The following is a description of a gene set: Limb joint contracture species: Homo sapiens Human Gene Set: HP_LIMB_JOINT_CONTRACTURE A contracture (chronic loss of joint motion due to structural changes in muscle, tendons, ligaments, or skin) that prevent normal movement of one or more joints of the limbs., and this is the list of marker genes: PDGFRB, CPT2, BCAS3, OSGEP, PSMB8, KY, PQBP1, FGD1, DLG5, PDXK, ERCC6, ACTG2, TGFBR1, PEX1, COX11, PIK3R2, CAPN3, ALG3, GABRD, COL11A1, SNUPN (NCBI Gene Id 10073), CDC45, SNAP25, F8 (coagulation factor VIII), COL11A2, NUP88, RERE, DVL3, SLC18A3, CCN2, KCNAB2, OCRL, RSPO2, ALG2, NFATC2, COL12A1, NXN, ORAI1, SCN4A, CADM3, ORC4, TRIM2, SMAD2, C18orf32, SMAD3, PHGDH, RTL1, KCNJ11 (NCBI Gene Id 3767), SNRPB, WDR26, UBE4B, FZD2, MED11, CRKL, SMG9, CTCF, INS, PYCR1, REEP1, KIF21A, IPO8, SLC29A3, DSP, TBX15, EIF5A, ERCC5, COG5, PYROXD1, HSPG2, L1CAM (NCBI Gene Id 4268), HNRNPA2B1, IRF5, PI4KA, SIGMAR1, FHL1, SMOC1, JARID2, FERMT1, PIGA, DDHD2, DPM1, MUSK, GNPAT, KRT1, HES7 (NCBI Gene Id 84667), PLEKHG5, GMNN, ARID1B, ALAD, TBX2, CSGALNACT1, HNRNPA1, HSPB1, DNM2, FBXO28, SPTBN4, OPA1, SLC26A2, TRPS1, RIPPLY2, IGHMBP2, NGLY1, KMT2A, FKBP10, MYOD1, EMG1, COG8, ASXL1, RBM28, TPRKB, PORCN, GDAP1, DYRK1A, HACD1, ADAMTSL2 (ADAMTS like 2), STAT3, ATP6V1E1, HINT1, SLC10A7, SPG11, FBN2, ERCC1, IGF2 (NCBI Gene Id 492304), PHF6, RTTN, HLA-DRB1, TMEM43, DOK7, GPC3, ALS2, MYOT, KLHL9, TNNT3, KIAA0319L (KIAA0319 like), SHH, KDM5B, MAGEL2, PDPN, TELO2, ANKLE2, ARX, TP63, RPL10, CNTNAP1, ALG14, TAF4, PRG4, PPP2R5D, ARPC4, KMT2B (NCBI Gene Id 9757), MAFB (MAF bZIP transcription factor B), PRKCZ (protein kinase C zeta), TPM3, CANT1, SMARCAD1, KAT6B, SUZ12 (NCBI Gene Id 23512), IDS, DDR2, SLC25A4, PAX3, ERLIN1, FGFR1, PNPT1, ALDH18A1, SLC35A3, TMEM222, LAGE3, SDHD, PIGL, FLNA, CCR6, MT-TE, NR4A2, ADSS1, ATR, UBAP2L, MEGF10, BRF1, LMBR1, LFNG, GFM2, UBA1, ZNF407, MMP2, SOX9, PLOD1, TFAP2A, BCOR, SLC39A14, PTH1R, SPTAN1, NEFL (NCBI Gene Id 4747), ZDHHC9, HK1, FUS, IL6ST, TGDS, IDUA, KRT9, LMBRD2, GJB2, ITGB4, TMEM70, SEPSECS, LUZP1, SLC12A6, NT5C2, ORC1, LARGE1, CNTN1, ZMPSTE24, B3GALT6, ERI1, SGCG, PTRH2, RYR1, GNS, SIN3A, YRDC, GLDN, OTUD6B (NCBI Gene Id 51633), CHRNG, DVL1, AMER1, ORC6, SPTLC1, PLAAT3, TUBA1A, ALX1, TUBB3, PMP22, KRT16, PDX1, LIFR, ABHD12, PSTPIP1, P4HTM, ERCC4, FKRP, TOR1AIP1, JUP, BCR, ZC4H2, NAA10, BAG3, PTDSS1, H4C9, WNT5A, MBTPS2, NUP107, CAMLG, NEDD4L, JAG2, ERGIC1 (NCBI Gene Id 57222), LGI4, SPEN, BICD2, FIG4, DHCR24, ADAT3, NSUN2, GNB2, SPEG, PIGN, ALX3, TMEM218, LMX1B, SLC25A19, NOG, SELENON, ASXL3, TBX3, MAP3K7, COL1A1, POLR3A, COL2A1, TWIST2, TOR1A, NLRP3, CCBE1, ATP5F1D, NIPBL, GNPTAB, ADAMTS3, ZBTB20, PLOD2, SLC39A13, CDC6, XYLT1, UPF3B, MED25, ERLIN2, TRPV4, WNT7A, PIK3C2A, SDHAF1, SLC4A10, COL6A2, VARS1, GJB6, TP53RK, SH3PXD2B, MTMR14, APC2, MMP23B, C19orf12, KRT14, ECEL1, SLC25A46, LMNA (NCBI Gene Id 7816), PIGY, DAG1, COL6A3, ABCC9 (NCBI Gene Id 102724274), HS2ST1 (NCBI Gene Id 9653), DLL3, SPRTN, WDR4, ERCC8, TDO2, GRIN1, STX5, MAP3K20, SRD5A3, MMP1, CDT1, MKS1, TGFB2 (transforming growth factor beta 2), RAPSN, GNPTG, UROS, MED12, ECE1, NALCN, MYL2, HOXD13, MYO9A, SMC1A, GJA1, FLVCR1, COL6A1, GNPNAT1, FILIP1, SLC35A2, SDHB (NCBI Gene Id 96200), LAMA2, SLC1A4, PEX6, CRPPA, GLI3, INF2, DMD, TGFBR2, FAT4, FKTN, MECP2, COL17A1, ABCC8, ANTXR2, BIN1, LAMB3, CUL4B, NEB, ROR2, TTN, SYT2, SVIL, MYL1, CHRNB1, KDM5C, ADAMTS15, ABCD1, AUTS2, ANO5, NDRG1, GCK, CRLF1, PEX5, GDF5, LBR (NCBI Gene Id 653311), SCARF2, ACTA1, RNU4ATAC, ITGA7, EMD, MORC2, GFPT1, FBXO11, SYNE2, RAB3GAP1, FDFT1, MECR, NUP133, WDR73, DPAGT1, MYH3, NSD1, CCN6, GON7, DHODH, HRAS, KIF22 (NCBI Gene Id 728037), MEG3, MEGF8, POLR3GL, SLC39A8, DHX16, CLCF1, SKI, MYL11, SDHA, GPC4, B3GAT3, CCDC22, GPKOW, TCTN3, FBXW11, MYBPC1, RARS2, TNNI2, TLK2, SLC6A9, PRDM16, IKBKG, NOD2, TBC1D2B, EZH2, KIF5A (NCBI Gene Id 84710), ESCO2, ADGRG6, PIEZO2, CASZ1, GARS1, SIK3, RMRP, UFC1, POR, SYNE1, ERCC2, DLK1, CHST3, KCNK9, PSAT1, TBR1, GJB1, EXTL3, SGCA, PLEC, TPM2, EFNB1, RAB23 (RAB23, member RAS oncogene family), COL7A1, POMT1, CDH3, MAPK1, FBN1, MARS1, RYR3, PLOD3, GMPPB, TGFB3, UNC80, COL25A1 (NCBI Gene Id 84570), CTDP1, MESP2, HEXB, FGFR3, CAV1, TNNT1, SCYL2